The following is a description of a gene set: Deadenylation of mRNA Mouse Gene Set: REACTOME_DEADENYLATION_OF_MRNA studied in species Mus musculus, and this is the list of marker genes: Cnot11, Eif4a2, Eif4e, Cnot1, Pan3, Cnot8, Paip1, Cnot2, Cnot4, Cnot10, Pan2, Cnot9, Pabpc1, Eif4g1, Eif4b, Tnks1bp1, Parn, Eif4a1, Cnot6, Cnot7, Cnot3, Eif4a3, Cnot6l